Given this list of marker genes SHISA4, MROH1, TRAPPC2L, FLYWCH1, PRIMPOL, REX1BD, CXCL8, ACBD6, FDXR, PUS7, EIF4EBP1, PLCB1, EPN2, ARHGEF4, THRA, ZNF697, ABHD12, IGSF23, EEIG2, MIF4GD, FLT1, UPB1 (NCBI Gene Id 51733), VWF, ABTB3, TESC, RUBCNL, XYLT2, PNKD, FCMR, CRTC3, SNRNP25, SAMD1, C16orf74, GPR162, TPP2, SYTL3, ARPIN, ZMYND10, TSPAN13, PDK4, SCCPDH, RFLNB, MAST4, HOMER3, ICMT, XYLT1, SPNS2, MVB12B, CXCL6, NRROS (NCBI Gene Id 375387), CD9, SPP1, ALDOC, IRF2BP2, DTX4, OLIG1, ACACB, SOX13, RASA3, IER5L, SMYD3, RNF125, MXI1, EHMT2, DCST1, PLCB3, MEAF6, H2AX, OSBPL5, KBTBD11, TEX2, HMOX1, IL9RP3, HEATR3, LLGL2 (NCBI Gene Id 3993), MAT2A, ADRB2, HDAC11, SYNE3 (NCBI Gene Id 79686), ANGPT1, DGKG, SLC25A40, ADAM15, ABCC5, CHST13, RELL1, FADS2, LPCAT4, CEP85L, CD101, CCND2, PPFIA4, ANGPT4, SEMA6C, KIT, CTNNBIP1, SPINT1, TEF, BIK, SLC25A36, PAQR4, APOLD1, PPM1H (NCBI Gene Id 57460), HIVEP3, TAB1, CX3CR1, DDX28, ATG4C, PHACTR1, POLR3K, here is a description of the gene set: BACKGROUND: Vaccine development for influenza A/H5N1 is an important public health priority, but H5N1 vaccines are less immunogenic than seasonal influenza vaccines. Adjuvant System 03 (AS03) markedly enhances immune responses to H5N1 vaccine antigens, but the underlying molecular mechanisms are incompletely understood. OBJECTIVE: We compared the safety (primary endpoint), immunogenicity (secondary), gene expression (tertiary) and cytokine responses (exploratory) between AS03-adjuvanted and unadjuvanted inactivated split-virus H5N1 influenza vaccines. In a double-blinded clinical trial, we randomized twenty adults aged 18-49 to receive two doses of either AS03-adjuvanted (n = 10) or unadjuvanted (n = 10) H5N1 vaccine 28 days apart. We used a systems biology approach to characterize and correlate changes in serum cytokines, antibody titers, and gene expression levels in six immune cell types at 1, 3, 7, and 28 days after the first vaccination. RESULTS: Both vaccines were well-tolerated. Nine of 10 subjects in the adjuvanted group and 0/10 in the unadjuvanted group exhibited seroprotection (hemagglutination inhibition antibody titer > 1:40) at day 56. Within 24 hours of AS03-adjuvanted vaccination, increased serum levels of IL-6 and IP-10 were noted. Interferon signaling and antigen processing and presentation-related gene responses were induced in dendritic cells, monocytes, and neutrophils. Upregulation of MHC class II antigen presentation-related genes was seen in neutrophils. Three days after AS03-adjuvanted vaccine, upregulation of genes involved in cell cycle and division was detected in NK cells and correlated with serum levels of IP-10. Early upregulation of interferon signaling-related genes was also found to predict seroprotection 56 days after first vaccination. CONCLUSIONS: Using this cell-based systems approach, novel mechanisms of action for AS03-adjuvanted pandemic influenza vaccination were observed. TRIAL: ClinicalTrials.gov NCT01573312. studied in species Homo sapiens Human Gene Set: HOWARD_NEUTROPHIL_INACT_MONOV_INFLUENZA_A_INDONESIA_05_2005_H5N1_AGE_18_49YO_1DY_DN from publication Howard LM, Hoek KL, Goll JB, Samir P, Galassie A, Allos TM, Niu X, Gordy LE, Creech CB, Prasad N, Jensen TL, Hill H, Levy SE, Joyce S, Link AJ, Edwards KM (PMID 28099485) Genes down-regulated in neutrophil 1d vs 0d in adults (18-49) after exposure to inactivated monovalent influenza A/Indonesia/05/2005 H5N1 split-virus vaccine, time point 1D, administered i.m.